The following is a description of a gene set: Genes up-regulated in T reg: FOX3P knockout versus wildtype. from publication Williams LM, Rudensky AY (PMID 17220892) Human Gene Set: GSE6681_DELETED_FOXP3_VS_WT_TREG_UP studied in species Homo sapiens Analysis of Foxp3 ablated peripheral regulatory T cells. Regulatory T cells require the expression of the transcription factor Foxp3 for thymic development. It is not known whether continuous expression of Foxp3 is required for the maintained function of mature regulatory T cells in the periphery. Results indicate changes to the regulatory T cell developmental program in the absence of Foxp3., and this is the list of marker genes: CA2, ZNF804A, CD72, SLC22A1, C11orf65, SPRED3, CXCR6, PDP2, UBE2L6, PCDHB1, GCNT3, MRS2, PLAC8L1, ARHGEF3, DCST1, AIFM2, USP9Y, PDCD7 (NCBI Gene Id 10081), BPIFB1, PTGS1, EFCAB3 (EF-hand calcium binding domain 3), ZFP57, NCALD, NUDT11, RPL39L, CDC45, TSSK4, TMEM102, PDHA2, TCF7L1, ARV1, WDR81, GAREM2, ANPEP, NRP1, EFNB3, DNAAF1, MAL, USP50, SDC2, UPK2, KDM5D, SPTBN2, IGHG1, MYPOP, SNCB, ZBTB8A, VANGL1, MAMLD1, DAG1, RHCG, GPX3, DNAJC6, SLC6A18, RNF17, DPM1, ZNF638, CCT8L2, CPLANE2, MARCHF10, PRR16, B4GALNT4, HSD3B1, ST6GALNAC1, C11orf52 (chromosome 11 open reading frame 52), RPL9, CD96, BTN1A1, SPOCK1, RAB40C, HAO2, ESM1, HS3ST6, RAMP2, UTS2R, F13A1, TMEM117, KPNA4, OR5P3, NPDC1 (NCBI Gene Id 56654), CFHR1, RAP1A, COL6A3, VSIG2, TNP2, TM4SF1, SRSF9, LIN28A, ABHD16A, DDX39A, KCNA2, VRK2, GALR1, PROK2, SLC52A2, NTNG1, TMC1, SLC6A1 (solute carrier family 6 member 1), E2F4, MYH1, LYPD5, TMEM45B, BRINP3, NKG7, RARG, CTSW, LONRF3, PPP3R2, KIAA0513, SCGB3A1, TMPRSS6, DRC3, ADGRL3, EVC, CBLC, GPRIN1, THBS4, SLC41A2, CSF3R, BATF2, KDR, PNMT, A2M, GPR12 (NCBI Gene Id 283535), C6orf132, BLOC1S6, GRHL2, GPR87, ABCC5, RETN, SSTR4, NSG1, STOM, NATD1, SYPL2, FAM216B, THEM4, ARMCX3, MOK, RPTN, SMIM6, KCNS2, SOX18, IL17A, MYOZ1, SLC27A5, KIRREL1, ARX, XKR8, C9, KANK2, CLDN18, IFTAP, IGFBPL1, AFF2 (NCBI Gene Id 2334), TSPAN15, CSMD1, TMEM191C, TRIQK, GJC3, UNC80, TMEM200A, SCN3B, STON2, GDF11, EVC2, SPACA4, RDH16, LURAP1, MSR1, DEXI, TRANK1, HID1, TMEM151A, IL20, RHO, EGLN3 (NCBI Gene Id 63900), FCGR3A, XCL1, TNFAIP8, NR1H4, LCAT, MAMDC2, FAM124B, FHIP1A, BEX2, PLA1A, KCNJ4, PABPC5, ZBTB45, SMOC1, BPIFB3, TNFSF9, KRT81, B3GALT5, ABCG8, KRT78, ATP1A3, LCE1A